Given this list of marker genes SLC7A3, SLC43A1, ATP13A3, SLC25A20, SLC47A2, SLC44A1, TSPO2, SLC3A2, SLC22A3, SLC16A9, SLC38A7, AQP8, SLC6A14, SERINC5, SLC43A2, SLC6A9, SLC66A1, SLC22A2, SLC1A4, SLC7A8, SLC22A1, SLC19A2, SLC7A10, SLC6A7, SLC36A1, SLC25A17, SLC36A3, SLC6A20, SFXN1, SLC6A6, SLC25A42, SLC47A1, SLC16A10, SLC7A7, SLC22A4, SLC44A5, SLC7A5, SFXN3, SLC22A15, SLC25A19, SLC36A4, SLC44A4, SLC22A16, SLC44A2, SLC18A3, SLC38A2, SLC38A6, SLC38A4, SLC7A6, SLC44A3, RHAG, SLC19A3, SLC38A1, SLC66A1LP (NCBI Gene Id 652000), SLC38A9, SLC5A7, SLC25A38, SLC38A5, SLC6A5, SLC25A26, SLC6A3, SLC1A5, SLC6A2, SLC25A29, SLC29A3, SLC1A1, SLC22A5, SLC29A4, SLC15A4, SLC1A2, FLVCR2, SLC32A1, SLC36A2, MFSD12, SLC7A1, SLC25A15, SERINC3, SLC25A2, SLC7A2, FLVCR1, SLCO1A2, SLC38A3 (NCBI Gene Id 10991), here is a description of the gene set: Human Gene Set: GOMF_ORGANIC_CATION_TRANSMEMBRANE_TRANSPORTER_ACTIVITY Enables the transfer of organic cations from one side of a membrane to the other. Organic cations are atoms or small molecules with a positive charge that contain carbon in covalent linkage. studied in species Homo sapiens